Given this list of marker genes NDUFB7, DEGS1, NDUFV1, ST3GAL5, BAD, HLA-J, HLA-B, DRAP1, HLA-G, NAPG, RABAC1, GPR137, ARF1, P4HB, PQBP1, OASL, here is a description of the gene set: The prognostic significance of FLT3 mutations in acute promyelocytic leukemia (APL) is not firmly established and is of particular interest given the opportunities for targeted therapies using FLT3 inhibitors. We studied 203 patients with PML-RARA-positive APL; 43% of the patients had an FLT3 mutation (65 internal tandem duplications, 19 D835/I836, 4 ITD+D835/I836). Both mutations were associated with higher white blood cell (WBC) count at presentation; 75% of the patients with WBC counts of 10 x 10(9)/L or greater had mutant FLT3. FLT3/ITDs were correlated with M3v subtype (P <.001), bcr3 PML breakpoint (P <.001), and expression of reciprocal RARA-PML transcripts (P =.01). Microarray analysis revealed differences in expression profiles among patients with FLT3/ITD, D835/I836, and wild-type FLT3. Patients with mutant FLT3 had a higher rate of induction death (19% vs 9%; P =.04, but no significant difference in relapse risk (28% vs 23%; P =.5) or overall survival (59% vs 67%; P =.2) at 5 years. In in vitro differentiation assays using primary APL blasts (n = 6), the FLT3 inhibitor CEP-701 had a greater effect on cell survival/proliferation in FLT3/ITD+ cells, but this inhibition was reduced in the presence of ATRA. Furthermore, in the presence of CEP-701, ATRA-induced differentiation was reduced in FLT3/ITD+ cells. These data carry implications for the use of FLT3 inhibitors as frontline therapy for APL. Genes down-regulated in acute promyelocytic leukemia (APL) patients with mutated FLT3. species: Homo sapiens from publication Gale RE, Hills R, Pizzey AR, Kottaridis PD, Swirsky D, Gilkes AF, Nugent E, Mills KI, Wheatley K, Solomon E, Burnett AK, Linch DC, Grimwade D, NCRI Adult Leukaemia Working Party (PMID 16105978) Human Gene Set: GALE_APL_WITH_FLT3_MUTATED_DN